Given this list of marker genes BHLHA9, MAP3K20, HOXA13, HOXD13 (NCBI Gene Id 7859), GPC4, GDF5, GLI3, FGFRL1, NSD2, FLNA, ABCC9, KCNJ8, PUF60, FGFR1, ROBO1, PIGG (NCBI Gene Id 54872), EIF4A3, CTBP1, KAT6A, NELFA, PTHLH, TPR, CHSY1, SALL4, IHH, FGFR2, NOG, MGP, CPLX1, GJA1 (NCBI Gene Id 7953), SF3B4, VAC14, ACVR1, BMP2 (bone morphogenetic protein 2), FIG4, CHST11, LETM1, ERF, BMPR1B, here is a description of the gene set: Human Gene Set: HP_APLASIA_HYPOPLASIA_OF_THE_HALLUX Absence or underdevelopment of the big toe. studied in species Homo sapiens Aplasia/Hypoplasia of the hallux